Given this list of marker genes Jup, Pkp3, Cdh1, Dsg3, Pkp2, Pkp1, Prkca (NCBI Gene Id 18750), here is a description of the gene set: studied in species Mus musculus Mouse Gene Set: GOBP_DESMOSOME_ASSEMBLY A cellular process that results in the aggregation, arrangement and bonding together of a set of components to form a desmosome. A desmosome is a patch-like intercellular junction found in vertebrate tissues, consisting of parallel zones of two cell membranes, separated by an space of 25-35 nm, and having dense fibrillar plaques in the subjacent cytoplasm.